Given this list of marker genes Slc35b2, Papss2, Slc26a1, Slc35b3, Papss1, Slc26a2, here is a description of the gene set: Mouse Gene Set: REACTOME_TRANSPORT_AND_SYNTHESIS_OF_PAPS Transport and synthesis of PAPS species: Mus musculus